Given this list of marker genes Sema4c, Bap1, Sema4b, Abcc5, Khnyn, Hapln1, Zfp488, Fbxw4, Mobp, Gal3st2, Cacna1b, Phactr3, Rora, Pcgf6, Gpatch8, Sema4d, Serpinb9d, Slitrk6, Grb10, Kcnip3, Nckap5l, Rhoq, Ulk3, Hif1an, Vps37b, Fam83h, Sgpl1, Dennd6a, Zfp408, Rasgef1a, Mapre2, Zbtb37, AU040320, Sarm1, Lactb, Dynlt3, Brip1, Zdhhc9, Lin28a, Ankrd50, Plekhm3, Neu1, Abhd6, Bnip2, Ptpn7, Ctnnal1, Ebf4, Kcna1, Tnfsf4, Scgb1b30, Gga2, Rbm20, Crb2, Rbak, Nkapd1, Cyp24a1, Abtb1, Cln6, Abcb11, Ttc29, Dus1l, Eif4ebp1, Sertad3, Rufy3, Borcs6, Ier2, P2rx4, Samd10, E2f2, Scn2b, Sh3tc2, Grhl1, Kcns3, Lrrc10b, Gtpbp2, Nhsl3, Slc25a35, Retreg3, Zbtb7a, Slc6a17, Cyyr1, Irf4, Stat3, Zswim5, Golga5, Cgref1, Gcnt1, Osbpl9, Prss33, Ier3ip1, Ppp2ca, Necab3, Tafazzin, Fam118a, Mfsd9, Sbno1, Alpk3, Trp53inp1, Dhx33, Bhlhe41, Prdm1, Tmem120b, Shtn1, Tmprss13 (transmembrane protease, serine 13), Zfp518a, Mcl1, Myt1, Tjap1, Tle3 (transducin-like enhancer of split 3), Arid3a, Cdc42bpg, Zfyve1, Hdac3, Sec14l2, Ercc6l2, Grsf1, Kbtbd13, Sh3bp5l, Eva1a, Ist1 (NCBI Gene Id 71955), Cyth1, Lin28b, Atp11a (ATPase, class VI, type 11A), Gpr153, Orc2, Lhx8, Tent5a, Klf13, Lrp4, Ppp2r5c, Kmt5c, Eaf1, Trem6l, Bmf, Slc35a4, D17H6S53E, Msrb3, Ubr7, Fut1, Syvn1, Blzf1, Zscan29, Elovl6, Dnajc14, Rbm7, Vps4b, Rap1a, Crem, Stard13, Zswim6, Ppp4r3a, Ptpn1, Tmtc2, Scn4a (sodium channel, voltage-gated, type IV, alpha), Tmem25, Frmd5, Atxn1, Tmem132e, Diras1, Ninl, Trim71, Mamdc2, Ndufs4, Cdc42se1, Cdc37l1, Ppm1h, Usp38, Dram2, Slc39a9, Sel1l, Podxl, Map3k11, Ppat, Bet1, Nipal4, Dtx4, Speg, Cgn, Enpep, Chtf8, Abhd3, Bak1, Mtf1, Kctd21, Sstr3, Arid3b, Lfng, Ikzf4, Ino80d, Ttc7, Bag4, Tnfaip3, Nfkbib, Anpep, Cbx7, Galnt14, Xirp1, Slc25a15, Grk4, Lclat1, Nr6a1, Tmem72, Tspan12, Plxna1, Il6ra, Daam1, Prdm2, Tgoln1, Mlf2, Cdh5, Nrm, Rfxank, Nin, Pafah1b1, Mfhas1, Gal3st2c (galactose-3-O-sulfotransferase 2C), Dvl1, Tbc1d1, Acer2 (alkaline ceramidase 2), Fam234b (family with sequence similarity 234, member B), Prtg, Ube2g1, Tor2a, Smurf1, Mfsd13a, Il16, Tbc1d8b, Npl, Pi4k2b, Zbtb34, Sptb, Jade2, Itga8, Suv39h1, Galnt5, Glb1l2, Zfp523, Lif, Rfx3, Osgep, Ets1, Vdr (vitamin D (1,25-dihydroxyvitamin D3) receptor), 2610528J11Rik, Dicer1, Triap1, Dock3, Alg6, Ahrr, Cntd1, Hic2, Ccnj, Pcsk7, Ceacam1, Klhl24, Klc2, Scarb1, Acads, Retreg2, Cnnm1, Casp2, Cdr2l, Nim1k, Zfp62, Ajuba (ajuba LIM protein), Kcnk10, Was (Wiskott-Aldrich syndrome), Eif1ad, Zfp704, Scara5, Ovol1, Tril, Tmem161b, Cdk19, M6pr, Tada3, Nbeal2, Cdk16, Nup210, Ncan, Man1b1, here is a description of the gene set: from publication Chen Y, Wang X (PMID 31504780) species: Mus musculus Genes predicted to be targets of miRBase v22 microRNA mmu_miR_125b_5p in miRDB v6.0 with MirTarget v4 prediction scores > 80 (high confidence targets). Mouse Gene Set: MIR_125B_5P